The following is a description of a gene set: species: Homo sapiens A reduction in immunoglobulin levels of the IgG2 subclass in the blood circulation. Decreased circulating IgG2 concentration Human Gene Set: HP_DECREASED_CIRCULATING_IGG2_CONCENTRATION, and this is the list of marker genes: KDM6A, ATM, CD247 (NCBI Gene Id 919), SH3KBP1, PIK3CD, KMT2D, ADA, EPG5, CD3G, CTPS1